Given this list of marker genes OTC, here is a description of the gene set: part of: OTC variants cause OTC deficiency Reactome Pathway: OTC leader sequence variants cause OTC deficiency studied in species Homo sapiens Ornithine transcarbamylase is a mitochondrially localized protein that is encoded by a nuclear gene and translated on free ribosomes in the cytosol. Targeting to the mitochondria depends on a 33 amino acid leader sequence at the N-terminus of the newly synthesized protein that is cleaved during transit through the mitochondrial membranes. Mutations in the N-terminal leader sequence destabilize the mRNA, decrease overall protein levels and interfere with correct localization and function.